The following is a description of a gene set: from publication Chaussabel D, Semnani RT, McDowell MA, Sacks D, Sher A, Nutman TB (PMID 12663451) Monocyte-derived dendritic cells (DC) and macrophages (MΦ) generated in vitro from the same individual blood donors were exposed to five different pathogens, and gene expression profiles were assessed by microarray analysis. Responses to Mycobacterium tuberculosis and to phylogenetically distinct protozoan (Leishmania major, L. donovani, Toxoplasma gondii) and helminth (Brugia malayi) parasites were examined, each of which produces chronic infections in humans yet vary considerably in the nature of the immune responses they trigger. Genes up-regulated in comparison of macrophages versus macrophages exposed to L.donovani. species: Homo sapiens Human Gene Set: GSE360_CTRL_VS_L_DONOVANI_MAC_UP, and this is the list of marker genes: ZNF451, UBE2L6, PSMB4, ZNF189, TAPBP, PDXK, PRDX2, PARP4, AHNAK, VASH1, PISD, POLR2J, CDH5, MISP, PTPN13, TXLNA, CEBPA, COX5A, SRSF7, MPHOSPH8, PTPRU, FOXN3, MYL6, CUL2, DUSP7, SLC7A4, PFN1, ALDH1B1, UQCR11, BLCAP, TMX4, UBE2I, KCNQ1, GNA11, GRSF1, PPP3CB, SLC25A5, MAP2K3, ATXN2, USP22, CHERP, PCCB, HYAL2, PC, EIF3E, CBY1, CD37, CLEC10A, ARMC8, CAP1, EIF3F, ELOC, HCLS1 (hematopoietic cell-specific Lyn substrate 1), UQCRQ, CHST15, KRT8, ERCC3, NDUFA1, GFUS, MPST, OS9, ATP5MF, ITGAM, RHCE, TBL3, PPBPP2, PPP1CA (NCBI Gene Id 5499), KHDRBS1, ARF5, BTN3A2, TUBA1A, HTR7, BCL7B, GCN1, FAM3A, VPS26C, LSM4, ADCYAP1R1, IFNA16, PAF1, CD302, GUSB, SLC18A1, MAPKAPK2, DIAPH1, OAZ1, PLXND1, SF3A3, PRCC, ZNF384, ZWINT, DAP, TAF10, ITGB1BP1, NCOR2 (nuclear receptor corepressor 2), UBA7, MARCO, GSTP1, ASB1, PSMB9, LDLRAD4, ACADVL, NEK2, ARRB2, HSF1, PIAS2, PPP1R10, MARCHF6, PLCG2 (NCBI Gene Id 5336), TBCB, BRINP1, ADAM15, STX5, JUP, CDC42BPA, RPS21, EEF2, HLA-DRA, CLEC16A, TMEM186, LPO, PLTP, PLEKHO2, EPHB2, ATP5PD, ZNF629, PPM1G (NCBI Gene Id 5496), HLA-DPA1, ELAC2, MYO1F (NCBI Gene Id 4542), AFF1, USF2, SNX1, MYBPC2, SLC4A7, SF1, AGPAT1, TUBGCP3, CYFIP1, CDA, SHC1 (SHC adaptor protein 1), ZFHX3, RALY, ESYT1, FADD, GOLGA1, GPC3, PLEKHM2, GPX2, AP1B1, MARS1, BTBD2, POLR2L, MRPL28, ESR1, TSPO, SDHB, ADGRG6, TMEM187, TPP1, SEC13, STK10, PELP1, FCN1, NUCB1, MKRN1 (NCBI Gene Id 392799), SLC43A1, STIM1, LRPAP1, CPVL, CCNI, SPARC, RNASE1, BTRC, STK38, PFKFB1, H1-0, MSMB, SDR39U1, CHMP1A, ACTN1, SLC7A7, FUCA1, SRRD, UQCRFS1, UROS, GNAI2, HK3, PPT1, DHX38 (NCBI Gene Id 9785), DNAH7, PDCD11 (programmed cell death 11), EIF3D (NCBI Gene Id 8664), RXRA, DDB1 (damage specific DNA binding protein 1), FZR1, CSNK2B, RABGGTA, GABARAP, ORC4